Given this list of marker genes MTMR3, DUSP19, DUSP26, DUSP16, DUSP22, DUSP13A, DUSP23, DUSP1, DUSP14, PPM1F, DUSP12, DUSP29, DUSP5, STYXL2, DUSP2, DUSP3, DUSP4 (NCBI Gene Id 1846), DUSP18, DUSP15, DUSP8, DUSP9, DUSP7 (dual specificity phosphatase 7), CDKN3, DUSP21, DUSP10, DUSP6, SBF1, DUSP13B, here is a description of the gene set: species: Homo sapiens Human Gene Set: GOMF_PROTEIN_TYROSINE_SERINE_THREONINE_PHOSPHATASE_ACTIVITY Catalysis of the reactions: protein serine + H2O = protein serine + phosphate; protein threonine phosphate + H2O = protein threonine + phosphate; and protein tyrosine phosphate + H2O = protein tyrosine + phosphate.